Given this list of marker genes Tnfsf15, Gm24234, Rpl17-ps4, Brinp1, Gm11220, Whrn (whirlin), Tnc, Akna, Gm25480, Gm11404, Tmem268, Atp6v1g1, Gm12911, Hmgb1-rs18, Tlr4, Gm11482, Gm11218, Tnfsf8, Gm11217, Tcp1-ps1, Aknaos, Astn2, Trim32, Gm11483, Tex48, 8030451A03Rik (RIKEN cDNA 8030451A03 gene), Gm23950, Gm11249, Pappa, Tex53, Gm23738, Gm24697, Gm11214, here is a description of the gene set: studied in species Mus musculus Mouse Gene Set: chr4C1